The following is a description of a gene set: studied in species Homo sapiens Activation of tumor necrosis factor receptor 1 (TNFR1) can trigger multiple signal transduction pathways to induce inflammation, cell proliferation, survival or cell death (Ward C et al. 1999; Micheau O and Tschopp J 2003; Widera D et al. 2006). Whether a TNF-α-stimulated cell will survive or die is dependent on the cellular context. TNF-α-induced signals lead to the activation of transcriptional factors such as nuclear factor-kappa B (NFkappaB) and activator protein-1 (AP1) (Ward C et al. 1999; Widera D et al. 2006; Tsou HK et al. 2012).<p> The binding of TNF-α to TNFR1 leads to recruitment of the adapter protein TNFR1-associated death domain (TRADD) and of receptor‑interacting protein 1 (RIPK1). TRADD subsequently recruits also TNF receptor-associated factor 2 (TRAF2). RIPK1 is promptly K63-polyubiquitinated which results in the recruitment of the TAB2:TAK1 complex and the IkB kinase (IKK) complex to TNFR1. The activated IKK complex mediates phosphorylation of the inhibitor of NFkappaB (IkB), which targets IkB for ubiquitination and subsequent degradation. Released NFkappaB induces the expression of a variety of genes including inflammation-related genes and anti-apoptotic genes encoding proteins such as inhibitor of apoptosis proteins cIAP1/2, Bcl-2, Bcl-xL or cellular FLICE-like inhibitory protein (FLIP) (Blonska M et al. 2005; Ea CK et al. 2006; Wu CJ et al. 2006; Chen C et al. 2000; Manna SK et al. 2000; Kreuz S et al. 2001; Micheau O et al. 2001). NFkB-mediated inhibition of cell death also involves attenuating TNF-induced activation of c-Jun activating kinase (JNK). Whereas transient activation of JNK upon TNF treatment is associated with cellular survival, prolonged JNK activation contributes to cell death. However, as caspases activate JNK quite efficiently, JNKs are also regularly stimulated in course of apoptosis without being essential for cell death (Wicovsky A et al. 2007). AP1-mediated gene induction results from activation of JNK via TRAF2 (not shown here) (Tsou HK et al. 2012). While pro-survival signaling is initiated and regulated via the activated TNFR1 receptor complex at the cell membrane, cell death signals are induced by internalization-associated fashion upon the release of RIPK1 from the membrane complex (Micheau O and Tschopp J 2003; Schneider-Brachert W et al. 2004; Tchikov V et al. 2011).<p>TNFR1-mediated transcriptional activity of NFkB is both antiapoptotic and highly proinflammatory and thus must be tightly regulated to prevent constitutive activation that leads to persistent inflammation and cancer (Ward C et al. 1999; Fujihara S et al. 2002; Pekalski J et al. 2013; Kankaanranta H et al. 2014; Shukla S and Gupta S 2004; Jackson-Bernitsas DG et al. 2007; Zhang JY et al. 2007). Multiple mechanisms normally ensure the proper control of NFkappaB activation including two negative feedback loops mediated by NFkappaB inducible inhibitors, IkB-alpha (NFKBIA) and ubiquitin-editing protein A20 (He KL & Ting AT 2002; Wertz IE et al. 2004; Vereecke L et al. 2009; Pekalski J et al. 2013). Reactome Pathway: TNFR1-induced NF-kappa-B signaling pathway part of: TNF signaling, and this is the list of marker genes: TAB2 (TGF-beta activated kinase 1 (MAP3K7) binding protein 2), XIAP, UBA52, IKBKG, CHUK, BIRC2, RIPK1, USP4, TAB3, USP21, RACK1, TNFRSF1A, RNF31, RBCK1, TRADD, TRAF1, RPS27A, BIRC3, SHARPIN, SPATA2, TRAF2, CYLD, TNF, USP2, UBB, IKBKB, OPTN, MAP3K7, TNFAIP3, OTUD7B, TAB1, OTUD1, UBC